The following is a description of a gene set: Human Gene Set: GOBP_APOPTOTIC_PROCESS_IN_BONE_MARROW_CELL The apoptotic process in cells in the bone marrow. species: Homo sapiens, and this is the list of marker genes: FGFR2 (NCBI Gene Id 2263), LEF1, PTH, BCL2L1, PLK2, MIR146A